Given this list of marker genes Slc25a19, Tpk1, here is a description of the gene set: This event has been computationally inferred from an event that has been demonstrated in another species.<p>The inference is based on the homology mapping from PANTHER. Briefly, reactions for which all involved PhysicalEntities (in input, output and catalyst) have a mapped orthologue/paralogue (for complexes at least 75% of components must have a mapping) are inferred to the other species. studied in species Mus musculus electronically inferred by orthology from the curated human pathway Reactome Pathway: Vitamin B1 (thiamin) metabolism part of: Metabolism of water-soluble vitamins and cofactors